The following is a description of a gene set: Human Gene Set: GSE15930_NAIVE_VS_48H_IN_VITRO_STIM_IFNAB_CD8_TCELL_DN Differentiation of naive CD8 T cells into cytotoxic effector cells requires three distinct signals- antigen (signal 1), costimulation -B7-1 (signal 2) and cytokine, either interleukin-12 or interferon-a/b (signal 3). Interaction of naive CD8 T cells with antigen and B7-1 programs cell division and proliferation whereas the presence of cytokines- IL-12 or IFNa/b promote survival, differentiation and memory establishment. In the absence of signal 3, the cells interacting with antigen/B7-1 undergo tolerance induction. The objective of this study was to elucidate the mechanisms how the provision of signal 3 promotes differentiation and averts tolerance induction in CD8 T cells. Trichostatin A is a pharmacological agent that inhibits histone deacetylase activity, hence regulating chromatin structure and gene expression and differentiation in many cell types. Gene signature profiles of IL-12, IFNa/b and trichostatin A stimulated cells were compared to elucidate the molecular mechanisms of gene regulation. Oligonucleotide microarray analysis is carried out to determine the extent and molecular nature of the CD8 T cell differentiation program induced by IL-12 or IFNa/b in concert with antigen and B7-1 signal. studied in species Homo sapiens Genes down-regulated in comparison of CD8 T cells at 0 h versus those at 48 h after stimulation with antigen-B7-1. from publication Agarwal P, Raghavan A, Nandiwada SL, Curtsinger JM, Bohjanen PR, Mueller DL, Mescher MF (PMID 19592655), and this is the list of marker genes: EZH2, TIMM8B, YARS1 (tyrosyl-tRNA synthetase 1), CDCA4, OGT, KIF22, NUP50, COX17, CDK4, MRPL36, PFKL, RUVBL2, EFTUD2, EXO1, CEBPZOS, BLMH, RRP1B, TIMM13, MRPL44 (NCBI Gene Id 65080), STOML2, MDFIC, LUC7L3, FH, MRPL17, PSMD7, PSMD5, MAT2A, SNRPC, NDUFA8, LMAN1, CFAP20, CLPP, BSG, SKIC8, SEPTIN2 (septin 2), POLR3K, HMGN5, PSMC1, TFAM, VEGFA, CKAP2, PEBP1, TMEM97, MRPS2, ACP1, TRIP13 (NCBI Gene Id 9319), PDCD2, HAX1, CPSF4, ALDH18A1, ELOF1, UQCC2, RSL24D1, ZSWIM1, EBP, NUP93, TIPIN, ARL3, B3GNT2, LARS1, KPNA3, CCT3, SLC25A17, NAA35, METAP1, IRF4, U2SURP, PMS2, DUS1L (NCBI Gene Id 64118), AK2, FXN, MARCKSL1, IFRD2, MRPS33, SNRPA, ARL5A, NDUFS5, FUBP1, DBI, CCNE2, DDX1, BUB1, MTHFD2, MRPL38, EXOSC7, DRG1, PDIA6, ADPRM, RAD23B, TOMM40, SSR2, CISD1, PPP1R7, SQLE, DPY30, MRPS18B, SF3A1, LSM2, PLSCR1, HMGCR (3-hydroxy-3-methylglutaryl-CoA reductase), CUL2 (cullin 2), GCSH, HCFC1, CDC34, IARS1, COQ7, LARP1, NCAPH, MRPL35, PRELID1 (NCBI Gene Id 27166), ATP5IF1, PITPNB, SEC23B, DNPH1, CCNC (NCBI Gene Id 892), PGM1, EIF6, MTERF2, MTCH2, MRPL13, PGD (NCBI Gene Id 5226), RRM2, MRPL12, ZNHIT1, ITPA, MYC, PLRG1, MRPS12, EXOSC10, TMEM208, HDDC2, PABPC4, EEF1AKMT1, MRPL20 (NCBI Gene Id 64994), EIF2B5, AURKA, ERG28, MCM7, TSPAN31, MARS1, PTCD2, TBRG4, UNC119B (NCBI Gene Id 84747), GUSB, GABARAPL1, USP39, RSPH3, CLCN3, ANKRD40, DCK, CENPC, NUTF2, SSNA1, PSMG1 (proteasome assembly chaperone 1), PRDX2, PCK2, FDX1, RER1, MRPS31, GART, DTD2, UBE2M, SMC2, ENOPH1, DPP3, EDEM3, PRPF31, RNFT1, RPRD1B, MRPS7, GARS1, G6PD, PHTF2 (NCBI Gene Id 57832), VCL, TNFRSF4, NDUFB8, PMPCB, NDUFAF1, RPN1, TARDBP, MRPL11, UGDH, TARS1 (NCBI Gene Id 94887), MRPS11, PCYOX1, NDUFB7, FARSA, ABCF1, HNRNPLL, BCAT1, NCAPH2 (NCBI Gene Id 96652), ALAS1, CDC6, UBE2S, PTGER2, ETF1, SS18L2, ORC6, GTF2H4, CHEK1